The following is a description of a gene set: Mouse Gene Set: MIR_106A_5P species: Mus musculus Genes predicted to be targets of miRBase v22 microRNA mmu_miR_106a_5p in miRDB v6.0 with MirTarget v4 prediction scores > 80 (high confidence targets). from publication Chen Y, Wang X (PMID 31504780), and this is the list of marker genes: Unk, Olfm1, Itgb8, Dnajc24, Zc3h12c, Plekha7, Armc8, Rab30, Trip10, Tasor, Slc17a8, Retreg2 (reticulophagy regulator family member 2), Slc16a9, Gabbr2, Heg1, Chmp4c, Lima1, Ahrr, Fsd1l (fibronectin type III and SPRY domain containing 1-like), Il25, Mapk4 (NCBI Gene Id 225724), Sobp, Nckap5, Suco, Xrn1, Klhl28 (NCBI Gene Id 76837), Rgma, Rest, Derl2, Vangl1, Sash1, Cast, Tmem127, Fjx1, Med12l, Gramd1a, Prepl, Mcl1, Ythdf3, Slc17a7, Smoc1, Ugdh, Ago1, Rbbp7, Ldlrap1, D030056L22Rik, Smad5, Ankrd17 (ankyrin repeat domain 17), Pcsk5, Myt1l, Sumf1, Ppp1r15b, Dpysl5, Slc22a23, Unkl, Ano5, Slc12a7, Ube3c, Nfat5, Atxn1l, Srpk2, 6430548M08Rik, Zfand4 (NCBI Gene Id 67492), Pkd2, Ezh1, Iqsec2, App, Map7, Fnbp1l, Dennd5b, Afg1l, Coro2b, Ankrd52, Zdhhc1, Ptchd4, Usp3 (NCBI Gene Id 235441), Bnip2, Tmed8, Nrip3, Gosr1, Aktip, Irf9, Frmd6, Srgap1 (NCBI Gene Id 67744), Gxylt1, Dock4, Dcbld2, Smyd1, Rap2c, Psd, Prrg1, Pcdhac2, Rab10, Dmtf1, Mknk2, Tafa1, Smoc2 (NCBI Gene Id 80628, SPARC related modular calcium binding 2), Hycc2, Septin2, Sh3bp2, Znfx1, Txnip, Nr4a3, Hbp1, Dpysl2, Kcnb1, Sqstm1, Rapgefl1, Usp24, Ppp1r21, Elk3 (NCBI Gene Id 319474), Map3k14, Pcdha1, Fgd4, Ism2, Mapre3, Fbxo28, Dusp2, Csnk1g1, Plekha3, Timp2, Dab2, Zhx2, Ulk1, Mier1, Pkd2l2, Wdr37, Pak5, Ssh2, Epha7, Cep120, Epha4, Purb, Lypd6, Sertad2, Ccdc71l, Bbx, Csrnp3, Dsg4, Napepld, Jazf1 (NCBI Gene Id 231986), Mkrn1, Brms1l, Col4a3, Nr2c2 (NCBI Gene Id 22026), Zfyve26, Fgd5, Sema4b, Creb5, Gab1, Cep57 (NCBI Gene Id 74360), Zfp236, Irf2bp2 (NCBI Gene Id 672960), Phip, Fibin, Rcan3, Pbx3, Hook3, Klf11, Tsg101, St6galnac6, Pkd1, Chrm2, Oxr1, Neurog3, Pls1, Sema7a, Zfp9, Arhgef10, Hlf, St6galnac3, Arhgap1, Dnal1, Ankrd13c, Mmp24, Unc80, Reep3, Zfp367 (NCBI Gene Id 238673), Vash2, Trappc2, Pcdha2, Rgmb, Hs3st5, Kcnk10, Camk2n2, Stx6, Itpripl2, Srcin1, Tph1, Tnfrsf21, Kpna2, Panx2, Tgfbr2, Cep97, Tnfaip1, Ptpn21, Pcdhac1, U2surp, Frs2, Fat4, Fyco1, Btg3, Rps6ka4, Tnks2, Pdgfra, Fam219b, Zfp91, Rab22a, Rassf2, Zfp827, Dennd10 (DENN domain containing 10), Npas2, Ptpn4, Zfp800, Nedd4l, Tmcc3, Kif5a, Rsrp1, Ginm1, Map3k8, Nek9, Osm, Trappc14, Rasl11b, Slc25a40, Zdhhc8, Bicd2, E2f5, Ube2q2, Pxk, Pcdha5, Rb1cc1, Fzd3, Myf5, Glis3, Pthlh, Tiam1, Btbd10, Zbtb9, St8sia2, Bcl11b (NCBI Gene Id 78682), Arhgap35, Gpr137b, Skor1, Tbc1d12, Pcdha7, Jpt1, Sos1, Rp2, Ddhd2, Idua, Map3k2, Smim5, Zbtb18, Rsbn1, Ncoa3 (NCBI Gene Id 99361), C2cd2, Kmt2b, Laptm4a, Retreg3, Tbc1d8b, Zfp148, Acer2, Wfs1, Midn, Clock, Trim36, Pcdha10, Pgbd5, 1600012H06Rik, Rnf150, St3gal1, Acsl4 (NCBI Gene Id 50790), F3, Lrch1, Camta2, Osr1, Ankib1, Sall1, Pdcd1lg2, Kif23, Mastl, Rnf6, Kcnq2, Pcdha12, Topors, Lhx6, Atxn7l1, Atg14, Pcdha9, Prr14l, Nbea, Lrrc55, Trip11, Mink1, Bmpr2, Arid4b, Tars2, Rgs17, Usp32, Abca1, Trpv6, Atg16l1, Sh3pxd2a, Agfg2, Pfkp, Mfn2, Rs1, Pcdha3, Lama3, B3galt2, Zfp704, Arhgef11, Adam9 (NCBI Gene Id 11502), Zbtb41, Col4a4, Aak1, Rundc1, Npat, Susd6, Flt1, Pafah1b1, Eri1, Creb1, Marchf8, Rasd1, Mospd2 (NCBI Gene Id 76763), Bnc2 (NCBI Gene Id 71498), Chd9, Pde3b, Nagk, Kif3b, Naa30, Slc2a4 (solute carrier family 2 (facilitated glucose transporter), member 4), S1pr1, Mosmo, Arhgap12, Pitpna, Tanc2, Kdm2a, Has2, Mex3d (mex3 RNA binding family member D), Crot, Akap13, Cfl2, Gid4, Tbcel, Rbl2, Zfpm2, Ankrd33b, Wdfy3, Bahd1, Ormdl3, Pcdha6, Fcho2, Rufy2, Crybg3, Fastk, Slc24a2, Prr15, Rasgrf2, Plxdc2, Tmem64, Akt3, Arhgap26, Atl3, Tle4, Ahnak, Tfb2m, Rhoc, Cd69, Socs6, Rnf2, Rab5b, Gpr137c, Spopl, Clip4, Map3k13, Zfp661, Kmt2a, Sar1b, Sybu, Atad2, Cc2d1a, Kat2b, Pcdha4, Snx8, Tbc1d9, Slc16a6, Polr3g, Sfmbt1, Cnot6l, Pcdha11 (NCBI Gene Id 12942), Sorl1, Ogfod2 (2-oxoglutarate and iron-dependent oxygenase domain containing 2), Ptpn3, Stxbp5, Ccng2, Scn1a, Ankrd9, Pkn2, Tnks1bp1, M6pr, Slc40a1, Rb1, Rab33b, Abcg4, Tmem267, Cbln4, Zfp512b, Mfap3l (NCBI Gene Id 71408), Ppp1r3b (NCBI Gene Id 330736), Foxj3, Spred1, Tspan9, Crk, Ano3, Map6d1, Gpc6, Ndel1, Slc49a4, Luzp1, E2f1, Zbtb4, Rnf128, Nanos1, Trim3, Uri1, Cdca7 (cell division cycle associated 7), Rps6ka1, Slc18a2, Cnot7, Usp46, 2510009E07Rik, Tet1, Arhgef18, Mtmr3, Enpp5, Fbxl5, Ntng1, Pcdha8, Limk1, Apcdd1 (adenomatosis polyposis coli down-regulated 1), Slc31a2, Fat2 (NCBI Gene Id 245827), Ddhd1, Rab11fip5, Gpr63, Egln3, Pex5l, Nabp1, Uevld, Rab8b, Map3k12, Ints14, Eif4a2, Reps2, Ppp1r3e, Gon4l, Rps6ka5, Sall3, Klf9, Mylip, Cmpk1, Lrp8, Snx16, Nup35, Fam13c, Pgm2l1, Lpgat1